The following is a description of a gene set: Human Gene Set: LEE_LIVER_CANCER_DENA_UP Genes up-regulated in hepatocellular carcinoma (HCC) induced by diethylnitrosamine (DENA). species: Homo sapiens from publication Lee JS, Chu IS, Mikaelyan A, Calvisi DF, Heo J, Reddy JK, Thorgeirsson SS (PMID 15565109) Genetically modified mice have been extensively used for analyzing the molecular events that occur during tumor development. In many, if not all, cases, however, it is uncertain to what extent the mouse models reproduce features observed in the corresponding human conditions. This is due largely to lack of precise methods for direct and comprehensive comparison at the molecular level of the mouse and human tumors. Here we use global gene expression patterns of 68 hepatocellular carcinomas (HCCs) from seven different mouse models and 91 human HCCs from predefined subclasses to obtain direct comparison of the molecular features of mouse and human HCCs. Gene expression patterns in HCCs from Myc, E2f1 and Myc E2f1 transgenic mice were most similar to those of the better survival group of human HCCs, whereas the expression patterns in HCCs from Myc Tgfa transgenic mice and in diethylnitrosamine-induced mouse HCCs were most similar to those of the poorer survival group of human HCCs. Gene expression patterns in HCCs from Acox1(-/-) mice and in ciprofibrate-induced HCCs were least similar to those observed in human HCCs. We conclude that our approach can effectively identify appropriate mouse models to study human cancers., and this is the list of marker genes: NUP205, GPC3, LCN2 (lipocalin 2), CD24, FABP4 (NCBI Gene Id 2167), TM4SF4, LGMN, VCAM1, DYNLT1, PEA15, S100A9, VNN3P, PPBP, PTPRE, IGFBP1, POU2AF1, COL4A5, RAD51B, KDELR3, ANXA1, CPE, CD63, ANXA5, LY6D, TLR1, LAMA5, KIFAP3, ABHD2, APCS, KIF11, PLEK, FBLN2, LY6E, MCM6, THBS1, COL4A1, TAGLN2, MMP12, CSN3, PLAT, TFF3, SOX9, B4GALT6, GATM, ANXA2, LEPR, CTSS, NDRG1, BCL2A1, SPP1, RGS2, MFGE8, ID1, NKTR, HOXC6, ANKRD1, LPL, COL4A2, NOTCH3, RPL36